Given this list of marker genes MCCC1, ADTRP, GALT, MBL2, CNOT1, C2orf42, CAPRIN2, AIMP1, ZFR, CAMK4, ILKAP, MRPL58, UBE3C, CHMP6, PNP, MRPL12, CHN1, RAD54B, NPDC1, REXO2, TXK, ADCK2, HERC1, DUSP10, MTCH2, MYH3, EPB41L2 (erythrocyte membrane protein band 4.1 like 2), ABCC10, LSM14A, CYB561, CLK4, CD81, TRAM1, DBR1, MAT2A, ZNF395, UNC119B, RPN2, PUM1, CDCA4, TMEM254, PRKCH, SLAMF1, PAAF1, PPP3CC, PSMD7, CDYL, NUDT1 (nudix hydrolase 1), CLIP4, GCLC, ZNF337, ZNF665, H2AC17, DDX51, WDR44, PTCD1, ZDHHC24, RPS15A, CTSH, TAF1D, GTPBP4, ARHGEF3, PDHA1, POLR3E, HEATR6, SMIM10L1, DOCK9, ECI1, EPHA1, ZBTB14, RPS3A, SLC12A7, SMC5 (structural maintenance of chromosomes 5), NOC2L, RARS1, TBC1D9B, ATIC, MTSS1, IGLL3P, NELFCD, PUS7, PPOX, WRAP73, CYP2E1, SIDT2, DNAAF5, BRWD1, AK2, FAM86C1P, ERAL1, OR7E36P, STXBP1, MEAK7, C1orf216 (NCBI Gene Id 127703), DNAJC16, ZNF432 (NCBI Gene Id 9668), FANCE (FA complementation group E), PTMA, DHPS, ADD3, NENF, HINT1, CLDN1, SEC61G, ETHE1, LSM2, CCNT2, ALDH18A1, ERGIC3, GLUD1, LARS1, ZNF266 (zinc finger protein 266), RIOX1, PDE3B, DPY19L1, CXCR5, TRAF1, R3HDM1, IL11RA, MAPRE2, PILRB, COQ4, ZRSR2, SLC35D1, CHD1L, XPO1 (exportin 1), RPS16, JHY, PTCD2 (NCBI Gene Id 79810), LRRN3, SRRT, LINS1, CYC1, MALT1, ATP6V1B1, DZIP3 (DAZ interacting zinc finger protein 3), NDUFAB1, TIA1, EIF2B3, TUBB, ZZZ3, STON1, S1PR1, GPR6, CCNC, IFNG, PRPSAP1, PARP2, CCNJ, PSMD1, SPATA6L, DYNC1I2, AKIP1, IL2RA, HSPBP1, SNRPF, GPBP1L1, EIF2B2, ETNK1, LGALS3BP (NCBI Gene Id 3959), HCFC1, SOD1, ZNF83, LRIG1, CD3E, EED, CEP68, SEH1L, GRIK4, FBXO21, NKAPD1, FXN, NTHL1, AIMP2, UQCRC2, NUP133, TRIAP1, RAN, TMEM204, RFX7, PIGO, TPP2, PLAG1, MEOX2, USP16, RPL13A, CCL5, PLA2G12A (NCBI Gene Id 81579), METTL18, TNFSF11 (TNF superfamily member 11), RPS23, LZTFL1, FLT3LG, RNMT, C1orf115, STARD7, MAZ, POLR3C, RPA1, ANP32B, here is a description of the gene set: from publication Jeffrey KL, Brummer T, Rolph MS, Liu SM, Callejas NA, Grumont RJ, Gillieron C, Mackay F, Grey S, Camps M, Rommel C, Gerondakis SD, Mackay CR (PMID 16474395) Human Gene Set: GSE3982_NEUTROPHIL_VS_CENT_MEMORY_CD4_TCELL_DN species: Homo sapiens Genes down-regulated in comparison of neutrophils versus central memory CD4 T cells. In the present study we used Affymetrix oligonucleotide microarrays to produce gene transcription profiles for the major leukocyte types in humans. This comprehensive dataset enabled us to not only establish which genes were expressed in each leukocyte type, but also which genes were expressed in each subset after activation. The used of a comprehensive dataset of gene profiles from all the major human leukocyte subsets enabled a novel and powerful means for identification of genes associated with single leukocyte subsets, or different immune paradigms.